Given this list of marker genes CITED2, SMAD9, TBX20, NKX2-5, MYH6 (NCBI Gene Id 4624), KCNK3, CAV1, GATA4, ACTC1, SLC34A2, BMPR2, TLL1, GATA6, here is a description of the gene set: studied in species Homo sapiens Pulmonary vascular resistance (PVR) more than 3 wood units, as defined by the current definition of pulmonary hypertension. 95% of individuals have a PVR of less than 2.4 wood units. Human Gene Set: HP_INCREASED_PULMONARY_VASCULAR_RESISTANCE Increased pulmonary vascular resistance